The following is a description of a gene set: species: Mus musculus Mouse Gene Set: chr11D, and this is the list of marker genes: D030028A08Rik, Krtap4-2, Krt23, Gm12359, Chad, Itga2b, Krt17, Atxn7l3, Gm12348, Gpr179, Gjd3, 4930405D11Rik, Krtap2-22, Gm11560, Gsdma, Luc7l3, Igf2bp1 (insulin-like growth factor 2 mRNA binding protein 1), Krt31, Smarce1, Tubg2, Grb7, Krtap1-5, Krtap4-24, Mlx, Snf8, Wnk4, Krtap9-20, Eme1, A430060F13Rik, Tmub2, Ormdl3, H1f9, Gsdma2, 4930417O22Rik, Gm14206, Hoxb8, Scrn2, Mycbpap, Rundc3a, Gm11541, Gast, Sp6, Gm11531, Ubtf, Mir5119, Plxdc1, Tmem106a, Gm11529, Brca1, Gm11584, Zpbp2, Ube2z, P3h4, Eif1, Krt27, Aarsd1, Jup, Ptges3l (prostaglandin E synthase 3 like), Krtap4-7, Hcrt, Epn3, Rdm1, Zfp385c, Krtap2-20, Gsdma3, Tbx21, Mir8101, Krt28 (NCBI Gene Id 70843), Spop, Fbxl20, Cdc34b, Gm44544, Psme3, Erbb2, Neurod2, Casc3, Mrpl27, Gm11557, Cnp, Mir10a, Kat7, Becn1, Krt36, Hoxb1, Hoxb5, Stxbp4, Bloodlinc, Krt42, Srsf3-ps, Gm11544, Cdc6, Gm22059, Krt25, Sp2, Ifi35, Hoxb6 (NCBI Gene Id 15414), Krt10, Nr1d1, Ppy, Stard3, Cd300lg, Gm24803, Cntd1 (cyclin N-terminal domain containing 1), Hoxb13, Krt13, Mir3063, Cisd3, Rapgefl1, Gm24725, Ghdc, Gm25113, Ppp1r9b, Epop, Xylt2, Etv4, Krtap29-1, Krtap4-26, Rsad1, Cfap97d1, Stat5b, Lrrc46, Wipf2, Gm11515, Nkiras2, Gm11604, Krt15, Krtap3-1, Rpl19, 4833417C18Rik, Krtap9-21, Npepps, Klhl10, Cacna1g, Mpp3, Mpp2, Gm11626, Hoxb2, Slc25a39, Rundc1, Wfikkn2, Gm11511, Gm11628, Cdk12, Krtap4-23, Psmb3, Gm11520, Gm23451, AA623943, Cavin1, Krt34, Atp5mc1, Krtap1-4, Pcgf2, Gm22762, Mllt6, Rpl23, Spmap1 (sperm microtubule associated protein 1), Gm12356, Psmc3ip, Ramp2, Ccdc200, Gm11613, Gm11513, Utp18, Gm11527, Itga3 (integrin alpha 3), Col1a1, Gm11625, Zfp652, Krt9, Krtap4-6, Pnmt, Gm11523, Ccr10, Gm11498, Dnajc7 (DnaJ heat shock protein family (Hsp40) member C7), Krtap31-2, Kcnh4 (NCBI Gene Id 631364), Snx11, Acsf2 (NCBI Gene Id 264895), Mir6930, Dhx58, Mir7235, Mir7116, Spag9, E130111B04Rik, Gm11543, Mrpl10, Mir196a-1, Krt12, Aoc2, Gm11571, G6pc1, Gm11525, Pnpo, Krtap9-22 (keratin associated protein 9-22), Krtap3-3, Krt33b, Gip, Klhl11, B230217C12Rik, Gm11528, Gm12349, Krtap4-8, Socs7, Krt14 (keratin 14), Pyy, Gm11592, 1700003D09Rik, Krtap9-3, Retreg3, Krt39, Nme1, Gm11533, Med1, Krt33a, Vps25, Coasy, Nxph3, Gngt2 (guanine nucleotide binding protein (G protein), gamma transducing activity polypeptide 2), Arhgap23, Rnd2, Gm25106, Samd14, Mbtd1, B230206L02Rik, Ttll6, Fbxo47, Krtap4-27 (keratin associated protein 4-27), Krtap3-2, Hoxb7, Ankrd40cl, Krtap31-3, Tmem92, Osbpl7, Tmem101, Hap1 (NCBI Gene Id 268486), Gm11516, Hspb9, Krtap9-1, Gm11536, Abcc3, Gm11598, Arl5c, Gm11597, Dhx58os, Pip4k2b, Gm25475, Nme2, Tom1l1, Gm11532, Fam171a2 (NCBI Gene Id 217219), Gm11539, Calcoco2, Krtap4-21, Hoxb9, Hrob, Tns4, Gm11633, Ikzf3, Lrrc3c, Dlx4os, Gm11545, Ankrd40, Krtap31-1, Nags, Kif2b, Tac4, Krt40, Krtap9-5 (NCBI Gene Id 435286), Lasp1, Snora21, Kat2a, Gm11506, Gm11635, Gm22423, Dhx8, Dlx3, Krtap17-1, Hdac5, Krtap4-20, Hoxb5os, A830036E02Rik, Skap1, Krt16, Igfbp4, Coa3, Pgap3, Gm10039, Kpnb1, Hsd17b1, Srcin1, Odad4, Meox1, Nbr1, Aoc3, Krtap4-1, 4930415H17Rik, Krtap4-9, Cbx1, Vat1, Grn, Asb16, Csf3, Ppp1r1b, 2410003L11Rik, Car10, Phb1, Naglu, Abi3, Fkbp10, Gm11502, Tcap, Mir8102, Mien1, Hoxb3os, Krtap16-1, Phospho1, Krt32, Gm11583, Fam117a, Gm11514, Copz2, Arl4d, Mir6927, Stat3, Mrpl45, Krt35, Hoxb4, Cwc25, Stat5a, Psmd3, Cacnb1, Krt24, Krtap4-13, Polr2k-ps, Gm11517, Top2a, Plekhh3, Ngfr, Thra (thyroid hormone receptor alpha), Gm11585, Krt222, Tbkbp1, Gm12358, Rara, Gm22456, Gm11619, Gm11551, Gm11524, Tob1, Krtap2-4, Gm11556, Dlx4, Slc35b1, Rpl27-ps2, Gm11586, Atp5l2-ps, Med24, Stac2, Mir152, Gm11546, Mir6928, Gm53, Cdk5rap3, Rab5c, Ezh1, Zfp652os, Krtap2-21, Ccr7, Gm11500, Spata20, Krtap1-3 (NCBI Gene Id 435273), Msl1 (male specific lethal 1), Tubg1, Krt19, Krtap4-25, Pdk2, Dusp3, Krt20, Cntnap1, Hoxb3, Sgca, Krtap4-16, Mir8103, Rpl27, Gm11501, G6pc3, Sost, Slc4a1, Nt5c3b, Acly, Krtap4-22, Nfe2l1, Prr15l, Lsm12, B4galnt2, Mir6929, Gm11518, 4933428G20Rik, Atp6v0a1, Krt26, Lrrc59, Cox11